Given this list of marker genes Septin2, D630045J12Rik, Cetn1, Kifap3, Adgrv1 (NCBI Gene Id 432787), Arl3, Tbcc, Kif17, Cep290, Tmem237, Ift57, Ush1g, Alpk1, Ush2a, Pcdhb22, Gnat1, Poc5, Bbs4, Pcdhb16, Ift20, Kif3a, Myo7a, Nphp4, Rp1, Ahi1, Ift122 (intraflagellar transport 122), Mak, Ift88, Cfap410, Lca5, Ttc8 (NCBI Gene Id 76260), Rpgrip1l, Iqcb1, Wdr19, Cetn2, Tsga10ip, Cetn3, Rp1l1, Nphp1, Topors, Whrn, Ift140, Sptbn5, Ift52, Fam161a, Rpgr, Spata7, Rpgrip1, here is a description of the gene set: Mouse Gene Set: GOCC_PHOTORECEPTOR_CONNECTING_CILIUM The portion of the photoreceptor cell cilium linking the photoreceptor inner and outer segments. It's considered to be equivalent to the ciliary transition zone. studied in species Mus musculus